Given this list of marker genes FUCA1, ASAH1, CPN1, ATP6V1C1, AEBP1, CPB2, HEXA, ATP6V1E1, ATP6V1B2, HEXB, CPB1, ATP6V1F (ATPase H+ transporting V1 subunit F), CPA1, GLB1, CTSA, GLA, NAGA, here is a description of the gene set: Human Gene Set: MODULE_492 Genes in the cancer module 492. species: Homo sapiens